The following is a description of a gene set: High confident estrogen up-regulated genes in non-MCF7/T47D breast cancer cell lines merged from 44 NGS datasets-based comparisons (10% topmost up-regulated genes and consistent in at least 40% comparisons). Human Gene Set: LI_ESTROGENE_NON_MCF7_T47D_E2_RESPONSE_DN from publication Li Z, Li T, Yates ME, Wu Y, Ferber A, Chen L, Brown DD, Carroll JS, Sikora MJ, Tseng GC, Oesterreich S, Lee AV (PMID 37272757) species: Homo sapiens As one of the most successful cancer therapeutic targets, estrogen receptor-alpha (ER/ESR1) has been extensively studied over the past few decades. Sequencing technological advances have enabled genome-wide analysis of ER action. However, comparison of individual studies is limited by different experimental designs, and few meta-analyses are available. Here, by ingesting large amount of E2-related transcriptomic data sets in breast cancer cell lines, we identified gene expression changes across 66 RNA-seq and 80 microarray experiments based upon the E2-induced fold change in gene expression. MCF7 and T47D cell lines have been used extensively as ER+ breast cancer models. However, extrapolation of this data to breast cancer is complicated by the known heterogeneity of breast cancer and potential biases arising from cell line-specific results. Importantly, while EstroGene contains transcriptomic data from 19 different breast cancer cell lines, data from MCF7 and T47D account for ~50% and ~20%, respectively, of all experiments. To characterize and describe contextual cell-line specific responses, we identified the top 10th percentile of upregulated and downregulated genes in an individual study and consistent among 50% of comparisons within MCF7 or T47D experiments. For non-MCF7/T47D experiments we lowered the threshold to 40% across studies due to the larger heterogeneity in this subset. Intersection of the three subsets yielded 89 and 96 uniquely regulated genes in MCF7 and T47D, we also identified genes that were not regulated in MCF7 and T47D but showed E2-induction in some other cell lines., and this is the list of marker genes: CITED2, NECTIN4, TRIB2, CORO2A, H2BC4, TNFSF10, PRSS8, IQGAP2